Given this list of marker genes MAPT, NSUN5P2, OPTN, YIPF1, VPS72, COX7A2L, PGAP4, GNPAT, COPS5, KRT10, CAP1, COBL, PKIG, AREL1, RELN, DCXR, PTOV1, EFR3A, PPP1R7, PSMC5, SPAG7, XPO7, ADAR, AHCY (adenosylhomocysteinase), YWHAQ, SOD1, SORL1, DYNC1H1, CPE, CLCN6, METAP1, HINT1, LRPAP1, TCFL5 (NCBI Gene Id 10732), NARS1, KBTBD11, PDHB, CNBP, HNRNPA3, B3GAT1, GPX4, PSMB3, SH3BP5, SNRNP40, TUBA4A, PRNP, PPP1R16B, CHST15, SCAMP3, RPS27, NAE1, TSG101, TTC1, VDAC3, CYFIP1, LMO3, TAF6, PRPSAP1, FEZ1, SF3B2, PMM1, PRDX6, IDI1, DENND4B (DENN domain containing 4B), CCT3, B4GAT1, SNU13, MOB4, UQCRC2, EFNB3, NPTXR, CANX, TCEAL1, PINK1, ATP5MF, HTRA1, RCAN2, RASL10A, COPS7A, CDIPT, ALDOA, TUBB4B, RNH1, NECAB2, SLC25A12, HNRNPK, EIF3D, TRAP1, LASP1, PSMC1, STXBP1, PIN1, CZIB, HSPA2, GRINA, PRRC2B, CRMP1, MARCHF2, VPS28, NDUFB3, FHL1, IP6K1, NDUFA6, SALL2, MARCKSL1, IMP4, EPHB6, AASDHPPT (NCBI Gene Id 60496), DPY19L2P2, SPTBN2, CREB3, OAZ1, TPGS2, RAB40B, SEM1, TALDO1, ATP6V0E2, BCL7B, HIVEP2, BAG6, PTS, RPL36AL, GPX1, CIRBP, ME3, HAGH (hydroxyacylglutathione hydrolase), CD99, AHSA1, SULT1A1, FKBP1A, PRDX1, MAGED1, ABCC5, ENO2, NDUFS3, LANCL1, EIF3K, CLIP3, CCK, ALDH2, PSME1, PSMB6, SLC25A11, KIF3C, OS9, TUBB2A, PEG10, INA, TAF10, PUF60, PCP4, ATP6V0D1, ERI3, RPL32, RPL10A, ATP1A3, TMBIM6, DEGS1, NCL, FBL, SLC25A4, POLR2E, FBXL2, FAU, GNAS, MRPL40, RPN1, SRP19, PUM2 (NCBI Gene Id 23369), CA11, PSAP, BEX4, RUSC1, NDUFB1, SULT4A1, MLLT11, PSME3, SMARCC2, APLP2, KATNB1 (NCBI Gene Id 10300), GGCT, AARS1, DDB1, GPR162, ARMCX2, ADGRB2, BAP1, RRAGA, RHOA, ISCA1, WBP2, ITPA, RTCB, TPI1, ARNT2, ALCAM, TAX1BP1, RTL8C, TUBB4A, PRKAR1A, RPL41, GRHPR, SLC7A5, CSRNP2, MIR9-1HG, CLNS1A, DSTN, UBB, UQCRC1, NDUFS4, CDK2AP1, RNF103, HMGN1, PSMA3, FABP7, TRIM37, FADD, COX7C, MICU1, MACROH2A1, PRPF8, TKT, FAN1, SYP, GLUD1, CHRDL1, ERP29, WDR7, IRAK1, IGFBP7, SRI, PSMD2, TARBP1, GOT1, SELENOW, RUNDC3A, DAD1, LYRM9 (LYR motif containing 9), ATP6V0C, RPS19, KLHL21, GLDC, CRYM, PSMD11, NDUFS8, EIF3G, NDUFAF3, RPL35, CACNG3, ASS1, PFN2, PNMA2 (NCBI Gene Id 11310), RUNDC3B, SCRN1, COX17, ANOS1, CALCOCO1, TIPRL, NDUFS7, MKRN1, ADD1 (adducin 1), SUMO1, CTCF, SLIT1, HYOU1, RPL4, NNAT, ATP5MC1, AKR1A1, STX7, TCEAL4, NSF, CAMK2G, APOD, CLSTN1, RNF11, SSR4, DGUOK, TMED10, TRIM28, SST, GOLGA8A, RABAC1, FAM131A, CDC16, CACNA1A, PDE2A, SUMO3, MIF (macrophage migration inhibitory factor), GARS1, VPS51, UBC, GLRB, DNM1, GABBR1, CCNI, FARSA, ATP6V1B2, UROS, SNRPE, ITGAE, GABARAPL2, EIF4B, MGST3, SCG2, CAPNS1, SERPINI1, CBX7, EEF1A1, LGALS1, BCL2L2 (NCBI Gene Id 599), SLC25A6, DCTN3, SYNGR3, ISCU, EEIG1, SLC25A46, MXRA7, CLTA, NISCH (NCBI Gene Id 11188), CX3CL1, LIPA, MAOB, PGRMC1, DHCR24, APLP1, PEX11B, AUH, ANXA6 (NCBI Gene Id 309), ATP5F1C, ALAS1, RASA1, IGBP1, ATP5PO, PRCP, MPC2, RAD23B, C1QBP, SARS1, COX6A1, ECH1, UTP14C, PAM, AP2B1, EXOC3, STK25, SNRPD2, DAZAP2, PFDN1, HPCA, PLAAT3, PMVK, FARP1, PSMB4 (NCBI Gene Id 5692), PHF24, MTMR6, PDXDC1, ADRM1, ACTR1B, RPL3, SRP14, RPS17, ATP6V0B, SLC25A3, RNF4, RPS24, CLTB, VPS52, ARPC3, PGK1, PSMA4, FKBP1B, CX3CR1, YARS1, ARHGEF18, COX7A2, BUB3, SDHA, HDGF, NFE2L1, TCEA2, S100A1, ITM2A, DTX4, KCNF1, TUBB3, RNF44, MIR124-1HG, TFE3, CAMK2B, ATP5PD, GNAI1, COX6B1, ENSA, NPC2, RPL37, PIP5K1C, RTN1, TIMM17B, ACADM, AKAP11, MYL12B, SCG5, LTA4H, NELL2 (neural EGFL like 2), TSPAN3, SLC30A9, ANAPC5, ASNS, SYT11, CDH18, LPIN2, MLX, NELFE, EIF3E, TUFM, PRAF2, ARF5, SEC16A, FIBP, UQCRH, STX1A, STIP1, SEPTIN2, TSNAX, SCAP, TSPAN7, FDPS, NDUFB5, CDK16, MLH1, PPP2R1A, BLCAP, ATOX1, UBA1, MAPK9, THY1, LARP1, SEC11A (NCBI Gene Id 23478), PHB2, SERPINE2, ATP2A2, ARL4A, UQCRB, PSMC2, UBE2E3, SF3B4, POLR2J, PISD, SDF2, COX6C, TMEM147, EPS15, CCT8, RPS27A, ALDOC, TSPYL5, AP3M2, SUB1, HNRNPAB, HSD17B10, EIF2B4, KIFAP3, SLC6A15, NRDC, CYC1, VIM, ELMO1, ARF3, PPP1R11, PPP2R5B, NMNAT2, PSMD12, PRUNE2, RPL7, IFIT1 (interferon induced protein with tetratricopeptide repeats 1), VSNL1, UCHL1, PTDSS1, MPP1, NDUFA1, PJA2, FGFR3, DCTN1, EIF3F, RPS18, PLCD1, CD81, EID1, SLITRK5, ENO1, YBX1, GABBR2, PTPRK, PRSS3, NUDT3, CAND2, RGS7, RPL24, AP2S1, EPHX1 (epoxide hydrolase 1), MPPED1, SMARCD3, HSPA12A, PNPLA6, STARD7, SUMO2, MYRIP, PFDN5, COX5A, CHL1, ECHS1, OGA, GOT2, ATP5MC3, EHBP1, SV2A, LZTR1, HRAS, RIMS3, PPP2R2A, SLC1A4, TOMM34, PAFAH1B3, RPS13, CHPF, MARCKS, PTPRT, ARHGEF17, OMG, PPP6C, KDM1A, NDUFC1, LPCAT4, CYFIP2, CAMSAP2, ACTG1, MLF2, NACA, ANKMY2, TUSC3, CUL1, DPYSL2, LZTS3, VPS8, FTL, CCND3, ITPKA, NPY, MSL1, NCDN, PKM, FOXG1, TENT4A, RPL27, DRG1, CABIN1, TRIB2, ACTR1A, SNTA1, IDH3B, CFL1, SRSF9, HSBP1, BMERB1, ATP6AP1, AP3B2 (NCBI Gene Id 8120), CNIH1, RAN, RPLP1 (NCBI Gene Id 6176), PSMD8, NUCB1, NDEL1, RPL11, TMEM59, ATP6V1F (ATPase H+ transporting V1 subunit F), GMFB, PFKM, ACADVL, PSMD7, PTPRM, UQCRQ, ATP6V1E1, NDUFAB1, KIAA0513, TRA2B, CSNK2B, GLO1, PSMD10, GRN, PSMB5, AKR1B1, GDI1, NDUFB8, UQCRFS1, CORO1A, NELL1, PTPRN2, ARFIP2, ABHD14A, DDHD2, CDK5, SUCLG1, RPS4X, RPL12, TCTA, RPS25 (NCBI Gene Id 6230), ARPC2, TCP1, DEK, PDIA3, XRCC5, RPS10, ACOT13, VBP1, HSP90B1, HPCAL1, R3HDM2, ARFGAP2, MAN2A2, BAIAP3, ATRNL1, SPINT2, UBA2, ENTPD6, PEBP1, GNPDA1 (NCBI Gene Id 9930), SEC61B, NPTX1, LAMTOR5, LDHB, KIFBP, RPS12, SNN, SEPTIN8, CORO2B, RNF187, CCT2, FTO, NECAP1, GYG1, SHOC2, CTBP1, NDUFA5 (NCBI Gene Id 80046), PFN1, NEDD8, NSG2, NONO (NCBI Gene Id 8253), TBCB, G3BP2, GSTO1, CAMK1G, NDUFV1, RPL29, APEX1 (NCBI Gene Id 328), CD200, SRP9, GABARAP, ARHGEF2, BAG1, C1orf216, P4HB, STK24, RPL8, BIN1, WIPF2, DDX1, CENPX, RABGAP1 (NCBI Gene Id 23637), AKT1, GNB1, NDRG4, MOAP1, CETN2, RPS6, STAU2, EIF6, MYL6B, DRAP1 (NCBI Gene Id 119810), AGPAT1, here is a description of the gene set: Cytoarchitectural abnormalities have been described in the prefrontal cortex of subjects with schizophrenia, bipolar disorder and depression. However, little is known about the gene expression profiles associated with these abnormalities. Genome-wide expression profiling technology provides an unbiased approach to identifying candidate genes and biological processes that may be associated with complex biological traits such as cytoarchitecture. In this study, we explored expression profiles associated with the abnormalities by using publicly available microarray metadata and cytoarchitectural data from post-mortem samples of the frontal cortex from 54 subjects (schizophrenia, n=14; bipolar disorder, n=13; depression, n=12 and controls n=15). Correlation analysis between genome-wide expression levels and cytoarchitectural traits revealed that genes were significantly correlated with a decrease in the number of perineuronal oligodendrocytes across all subjects. A total of genes were significantly correlated with a decrease in density of calbindin-positive interneurons across all subjects. Multiple biological processes including cellular metabolism, central nervous system development, cell motility and programmed cell death were significantly overrepresented in both correlated gene lists. These findings may provide novel insights into the molecular mechanisms that underlie the cytoarchitectural abnormalities of perineuronal oligodendrocytes and calbindin-containing GABAergic interneurons in the prefrontal cortex of the major psychiatric disorders. studied in species Homo sapiens Genes whose expression significantly and positively correlated with oligodendrocyte density in layer VI of BA9 brain region in patients with bipolar disorder. from publication Kim S, Webster MJ (PMID 18762803) Human Gene Set: KIM_BIPOLAR_DISORDER_OLIGODENDROCYTE_DENSITY_CORR_UP